Given this list of marker genes Sorbs1, Etv5, Mesd, Dvl1, Agrn, Lrp5, Musk (muscle, skeletal, receptor tyrosine kinase), Dnaja3, Crkl, Lrp4, Fzd9, Fnta, Rac1, Dok7, Crk, Rapsn, Rer1, Ptn, Colq, Sorbs2, Farp1, here is a description of the gene set: Mouse Gene Set: GOBP_SKELETAL_MUSCLE_ACETYLCHOLINE_GATED_CHANNEL_CLUSTERING species: Mus musculus The accumulation of acetylcholine-gated cation channels in a narrow, central region of muscle fibers, in apposition to nerve terminals.